Given this list of marker genes ABCC9, LRRC52, FHL1, AKAP9, ANK2, AKT1, LRRC26, LRRC38, LRRC55, here is a description of the gene set: studied in species Homo sapiens Human Gene Set: GOMF_POTASSIUM_CHANNEL_ACTIVATOR_ACTIVITY Binds to and increases the activity of a potassium channel, resulting in its opening.